The following is a description of a gene set: Human Gene Set: HP_INTRAMUSCULAR_HEMATOMA Intramuscular hematoma Blood clot formed within muscle tissue following leakage of blood into the tissue. studied in species Homo sapiens, and this is the list of marker genes: F13A1, SERPINE1, F10, SERPINF2, F13B, F8, F2, F7 (NCBI Gene Id 14068)